The following is a description of a gene set: Human Gene Set: HP_CHRONIC_LYMPHATIC_LEUKEMIA studied in species Homo sapiens Chronic lymphatic leukemia A chronic lymphocytic/lymphatic/lymphoblastic leukemia (CLL) is a neoplastic disease characterized by proliferation and accumulation (blood, marrow and lymphoid organs) of morphologically mature but immunologically dysfunctional lymphocytes. A CLL is always a B-cell lymphocytic leukemia as there are no reports of cases of T-cell lymphocytic leukemias., and this is the list of marker genes: LSM11, TET2, SRSF2, KIT (KIT proto-oncogene, receptor tyrosine kinase), SAMHD1, RNASEH2A, RNASEH2B, RNASEH2C, IFIH1, ADAR, PTPN6, TREX1, MEFV, ASXL1, RNU7-1, PIK3R1